Given this list of marker genes LRRC49 (NCBI Gene Id 54839), PRX, VIPR1 (vasoactive intestinal peptide receptor 1), ARC, SEMA7A, NEDD4L, TBX2, GNG7, S100A3, PRICKLE2, SLC12A2, ZBTB16, RNF24, NCKIPSD, VASN, TRPV2, SLCO2A1, RGS9, EVA1B, CD83, PKIA (cAMP-dependent protein kinase inhibitor alpha), ITGA1, TAGLN3, CDH8, XKR6, TBXA2R, DISP1, MIER2, MYLK, IL12A, ULBP2 (NCBI Gene Id 89934), PLXNC1, NCALD, HOPX, BTBD3, B3GALNT1, GRID1, TMEM108, ADIRF, ADAMTSL2, F2RL3 (F2R like thrombin or trypsin receptor 3), OAS2, PRDM1, KITLG, MPPED2, APLN, TBC1D20, DYRK2, ITGA3, TNFRSF4, KHDRBS2 (NCBI Gene Id 202559), ZNFX1, HOXB5, KCNN2, CYB561, PSEN2, LMO7, ITGA4, SULT1A1, PDE1C, S100A4 (S100 calcium binding protein A4), LAMA5, SPRED2, ARHGAP6, ADAMTS1, ATF3, GPR4, MGLL, NOS2, RILPL2, CDH13, SPRY4, MATK, EHD3 (NCBI Gene Id 30845), DPEP1, TNS3, LRRC36, CDKAL1, SPON2, PHLDB1, EDNRB, RARG, COLEC10, HLX, TBX2-AS1, SYNM, GBP1, here is a description of the gene set: Aerocyte species: Homo sapiens Human Gene Set: HE_LIM_SUN_FETAL_LUNG_C3_AEROCYTE from publication He P, Lim K, Sun D, Pett JP, Jeng Q, Polanski K, Dong Z, Bolt L, Richardson L, Mamanova L, Dabrowska M, Wilbrey-Clark A, Madissoon E, Tuong ZK, Dann E, Suo C, Goh I, Yoshida M, Nikolić MZ, Janes SM, He X, Barker RA, Teichmann SA, Marioni JC, Meyer KB, Rawlins EL (PMID 36493756)